Given this list of marker genes CACNA1D, RANGRF, CACNB2, ANK3, SLC8A1, GJA5, SCN4B, SCN2B, CAV3, HCN2, SCN5A, MIR208A (NCBI Gene Id 406990), KCNJ2, ATP1A2, TRPM4, SLMAP, HCN4, CACNA2D1, SCN1B, CACNA1C, ANK2, CACNA1G (calcium voltage-gated channel subunit alpha1 G), SCN3B, here is a description of the gene set: Human Gene Set: GOBP_MEMBRANE_DEPOLARIZATION_DURING_CARDIAC_MUSCLE_CELL_ACTION_POTENTIAL The process in which cardiac muscle cell membrane potential changes in the depolarizing direction from the negative resting potential towards the positive membrane potential that will be the peak of the action potential. species: Homo sapiens